The following is a description of a gene set: from publication Hinrichs CS, Borman ZA, Cassard L, Gattinoni L, Spolski R, Yu Z, Sanchez-Perez L, Muranski P, Kern SJ, Logun C, Palmer DC, Ji Y, Reger RN, Leonard WJ, Danner RL, Rosenberg SA, Restifo NP (PMID 19805141) Effector cells for adoptive immunotherapy can be generated by in vitro stimulation of naïve or memory subsets of CD8+ T cells. While the characteristics of CD8+ T cell subsets are well defined, the heritable influence of those populations on their effector cell progeny is not well understood. We studied effector cells generated from naïve or central memory CD8+ T cells and found that they retained distinct gene expression signatures and developmental programs. Effector cells derived from central memory cells tended to retain their CD62L+ phenotype, but also to acquire KLRG1, an indicator of cellular senescence. In contrast, the effector cell progeny of naïve cells displayed reduced terminal differentiation, and, following infusion, they displayed greater expansion, cytokine production, and tumor destruction. These data indicate that effector cells retain a gene expression imprint conferred by their naïve or central memory progenitors, and they suggest a strategy for enhancing cancer immunotherapy. Genes down-regulated in comparison of rested memory CD8 T cells from pmel-1 mice versus rested naive CD8 T cells from pmel-1 mice. studied in species Homo sapiens Human Gene Set: GSE16522_MEMORY_VS_NAIVE_CD8_TCELL_DN, and this is the list of marker genes: HENMT1, PHLPP1, CNOT11, SNX11, NQO1 (NCBI Gene Id 4834), ZFPL1, HSPA1B, HDGF, TLE3, POM121L2, USP24, KIAA0513 (NCBI Gene Id 9764), IL10, LORICRIN, BST2, KSR1, KMT2D, GPR182, LRCH1, HNRNPC, CNR1, ABCA3, ZMYM1, DSP, ID1, EIF4EBP1, LAG3, GARS1, GARNL3, SFTPB, IL1R2, OR7C1, PDCD2, ABLIM2, MFAP4, CD86, CNN3, PRRG4, ZDHHC23, ACOD1, AGRN, INSYN2A, FGF18, TMC7, PLCXD2, STX1A, NDRG1, CPD, ACACA, MAP3K5, EML5, NOTCH1, TMEM65, IFIH1, UTP14A (UTP14A small subunit processome component), EPHA2, NCKIPSD, FBXL3 (NCBI Gene Id 26224), SLC6A2, SLA, EPS8, EPPK1, SPPL2B, PTPN14, SYDE2, PHGDH, LGR6, CSE1L, VPS54, MYO1C, FKBP11, IZUMO1R, CAVIN1, IGF1R, RNF149, PPP1CB, CRACD, BSND, PDZK1IP1, ADH4 (NCBI Gene Id 127), FHDC1, ST3GAL2, NFKBID, TET2, SLC13A3 (NCBI Gene Id 64849), ETV6, GOSR2, RBBP7, SPHK1, PTPRS, MST1R, PSME1, F10, NMT2, SLC38A1 (NCBI Gene Id 81539), MYL10, PITHD1, RHOV, SLC41A1, DDR1, ATF2, RYR3, RAB11FIP1 (NCBI Gene Id 80223), RGS9, GPR18, IL1A, MEIS3, ZRANB2, NFIX, DNAH17, ADAM10, EPCAM, GP1BB, SMKR1, FADS6, EIF3C, ZMPSTE24, ARHGDIG, MARCHF10, SF3A3, B3GNT4, STAT5B, DYDC2, SAMD4A, CASS4, PTPRK, IRAG2, TRIB2, RFLNA, SLC25A1, CRHR2, DND1, NCKAP1, CTSV, RSBN1, ZAP70, TBX21, RALGDS, RND2, CDYL2, ATXN7L1, DHX34, CRB1, RBMX, ECM1, RAD9B, PPP1R37, AHCYL1, STARD3, IL36B, CASP1, RAN, PIERCE1, JAK2, LYPD8, TNS1, SLTM, PPP2R3A, GPR50, EGLN3, PTMS, LHFPL2, TMEM191C, ASXL1, TRIB3, SMG5, PRODH, USP37, RIPK4, NCF1, CD160, LRRTM1, UBALD2, KRTAP7-1, CAPRIN1, NFE2L3, ADAT2, LUC7L3, F3, EXO1, S100A5, PIK3CA, ALDH18A1, TOMM20L, FAS, ZNF703, DISP2, DCST1, LAMC2, SLC7A3, PSMD11, AAMP, CD200, KRTAP11-1, KCTD17, NAP1L1, BCL9, PSPH, NRP1 (neuropilin 1), WDR83OS